Given this list of marker genes CHRND, CHRNA2, CHRNB2, CHRNB4, CHRNG (NCBI Gene Id 1146), CHRNE, CHRNB3, CHRNA6, CHRNA3, CHRNA1, CHRNA9, CHRNA4, CHRNA7, CHRNA5, here is a description of the gene set: Nicotinic acetylcholine receptors are found in the postsynaptic terminals and these receptors are responsible in mediating postsynaptic currents. Most common types of neuronal postsynaptic nicotinic acetylcholine receptors are homomeric alpha 7 containing acetylcholine receptors. The densities of acetylcholine receptors are found to be similar to NMDA and AMPA receptors at these sites. Nicotinic acetylcholine receptors may permit both sodium and calcium ions, however, the ratio of sodium and calcium influx makes the receptors either highly sodium permeable or highly calcium permeable. species: Homo sapiens Reactome Pathway: Postsynaptic nicotinic acetylcholine receptors part of: Acetylcholine binding and downstream events